Given this list of marker genes ZW10, KIF5B, KIF4B, KIF2A, RAB6A, KLC2, ACTR10, TUBB4A, ARFGAP2 (NCBI Gene Id 84364), KIF1C, SEC22B, PLA2G6, TUBB4B, KDELR3, KIF1B, DYNLL2 (NCBI Gene Id 140735), ARF1, KIF12, TUBB2B, KIF18A, KIF18B, ACTR1A, KIFAP3 (NCBI Gene Id 22920), TMED2, DCTN3, KIF11, ARFGAP1, TUBA3E, KIF21A, KIF21B, COPE, SURF4, STX18, TMED3, RACGAP1, KIF20A, ARCN1, GALNT1, PAFAH1B2, TUBB2A (tubulin beta 2A class IIa), BICD1 (BICD cargo adaptor 1), DYNC1I1, CAPZB, CAPZA1, TUBB1, DCTN5, KIF4A (NCBI Gene Id 55595), KDELR1, COPB2, NAPG, KIF2B, TUBA1B, COPZ2 (NCBI Gene Id 51226), KIF26B, TUBA4A, TUBA8, TMED10, TUBB6, DCTN6, KIFC2, KLC3, KIF13B, KIF16B, ARF3, RINT1, NBAS, TMED9, BNIP1, DCTN2, RAB1B, CENPE, TUBA3D (NCBI Gene Id 150778), KLC4, RAB3GAP2, KIF27, NAPB, DCTN4, KIF15, TUBA1A, TUBAL3, KIF1A, DYNC1LI2, KIF3B, GBF1, KIF19, TUBB3, KIF9, DYNLL1, RAB1A, KIF5A, KIF3A, COPB1, TUBA3C, USE1, KIF22, DYNC1I2, KDELR2, KLC1, ARFGAP3, KIF23, NSF, GALNT2, RAB18, KIFC1, PAFAH1B1, BICD2, TUBB8, RAB3GAP1, COPG2, COPZ1, TUBA1C, PLA2G4A, KIF25, DYNC1H1 (NCBI Gene Id 992), DCTN1, KIF6, CAPZA2, KIF2C, AGPAT3, KIF26A, TUBA4B, TUBB8B, KIF20B, PAFAH1B3, COPA, ARF5, ARF4, RAB6B, TMED7, KIF3C, CAPZA3, NAPA, DYNC1LI1 (NCBI Gene Id 51143), COPG1, here is a description of the gene set: Golgi-to-ER retrograde transport studied in species Homo sapiens Human Gene Set: REACTOME_GOLGI_TO_ER_RETROGRADE_TRANSPORT